Given this list of marker genes FCGR1A, PAXBP1, NFKBIA, MAPKAPK2, PON2, MRC1, CTSV, MET, WASHC3, MCEE, RPS5, NPC2, PIP4K2A, SUPT4H1, SLC35A1, BUD31, EIF3K, SMARCD2, PES1, UQCRC1, UEVLD, SERINC3, PSMC3, SLC6A12, STK39, RBM17, ZKSCAN1, TRAFD1, YPEL3, RPL23A, NMI, GNB3, VRK3, CXCL12, ISYNA1, CCN2, NICN1, ACAA2, USE1, ELMOD3, BMP15, ZNF622, WDR6, EIF2B2, NME3, LPCAT3, MTNR1A, PKIG, SEMA3C, IGFBP4 (insulin like growth factor binding protein 4), DHRS7, CPNE1, PTGFRN (NCBI Gene Id 5738), C11orf16, CNTN3, COL11A1, GABRG3, H2BC18, CHIC1, S100A8, IRF7 (interferon regulatory factor 7, NCBI Gene Id 3665), CD48 (CD48 molecule), SPINK1, ITM2B, WASHC2A, CFP, PARP1, IL10RA, MTHFR, TM2D3, PFN2, MRPL24, DBN1, CMTM6, LRRC8A, IFIT3, HSP90AB1, RPS18, MS4A6A, HPGD, SSBP2, ZMYND8, RNASET2, RPS19 (NCBI Gene Id 8378), GNA14, RHOH, PMS2, MRPL27, DDC, GLO1, LGALS3BP, SPEF1, LYL1, MX2, MAF1, WDR45, CSNK2B (NCBI Gene Id 257616), ZNF274, GBP2, RPLP1, NECAP2, HGSNAT, HSD17B11, EPRS1, ZFP36L1, LY6E, HSPA1B, GAS6, AGRN, SELENOK, ILVBL, ACAA1, PFKM (NCBI Gene Id 5215), ECI2, ALDH1A3, ITSN1, CD40, DAP3, CCR5, PSMB10, FBXO9, LDHC, AP3D1, RABGGTA, NDUFA2, LMO2, GNA12, MAB21L2, FBXW4, TFAM, ZNFX1, ELOA, HSD17B4, OTUD7B, C4BPA, ZNF740, APBB1IP, RPL13A (NCBI Gene Id 94020), RPS10, CLK4, PRAP1 (NCBI Gene Id 118471), IFIT2, PSME1, TLR7, TAB3, SARAF, UBAP2L, MRPS21, JAK1, NISCH, FGF11 (fibroblast growth factor 11), ATP1A1, SERPINB6, FERMT3, IRF1, PSAP, ISG15, CDK2AP2, DBI, MIF4GD, NNT, DUSP16, TCN2, RPS23, IPP, UNC93B1, ALDH2, CMPK2, XPC, CGA, FCRLA (NCBI Gene Id 84824), DCTN6, NF1, RAB5C, LGALS9B, PDCD7, SLC15A2, TFF2 (NCBI Gene Id 7032), UQCRHL (ubiquinol-cytochrome c reductase hinge protein like), RETSAT, SESN1, STAB1, PRDX4 (NCBI Gene Id 82852), FH, LARP4B, GTF2I, NDUFS4, METTL9, TPK1, RELL1, OXCT1, ELP3 (elongator acetyltransferase complex subunit 3), YBX1, KIT, ASIC5, CLTA, TNRC6A, RNASE4, TMEM45A, GLMP, here is a description of the gene set: Genes up-regulated in monocytes treated by rosiglitazone: Ly6C high versus Ly6C low. from publication Gautier EL, Chow A, Spanbroek R, Marcelin G, Greter M, Jakubzick C, Bogunovic M, Leboeuf M, van Rooijen N, Habenicht AJ, Merad M, Randolph GJ (PMID 22855714) PPARγ is known for its anti-inflammatory actions in macrophages. However, which macrophage populations express PPARγ in vivo and how it regulates tissue homeostasis in the steady state and during inflammation is not completely understood. We show that lung and spleen macrophages constitutively expressed PPARγ, while other macrophage populations did not. Recruitment of monocytes to sites of inflammation was associated with induction of PPARγ as they differentiated to macrophages. Its absence in these macrophages led to failed resolution of inflammation, characterized by persistent, low-level recruitment of leukocytes. Conversely, PPARγ agonists supported an earlier cessation in leukocyte recruitment during resolution of acute inflammation and likewise suppressed monocyte recruitment to chronically inflamed atherosclerotic vessels. In the steady state, PPARγ deficiency in macrophages had no obvious impact in the spleen but profoundly altered cellular lipid homeostasis in lung macrophages. Reminiscent of pulmonary alveolar proteinosis, LysM-Cre x PPARγflox/flox mice displayed mild leukocytic inflammation in the steady-state lung and succumbed faster to mortality upon infection with S. pneumoniae. Surprisingly, this mortality was not due to overly exuberant inflammation, but instead to impaired bacterial clearance. Thus, in addition to its anti-inflammatory role in promoting resolution of inflammation, PPARγ sustains functionality in lung macrophages and thereby has a pivotal role in supporting pulmonary host defense. studied in species Homo sapiens Human Gene Set: GSE32034_LY6C_HIGH_VS_LOW_ROSIGLIZATONE_TREATED_MONOCYTE_UP